The following is a description of a gene set: Mouse Gene Set: GOBP_NEGATIVE_REGULATION_OF_CHOLESTEROL_EFFLUX species: Mus musculus Any process that decreases the frequency, rate or extent of cholesterol efflux. Cholesterol efflux is the directed movement of cholesterol, cholest-5-en-3-beta-ol, out of a cell or organelle., and this is the list of marker genes: Apoe, Srebf2, Irak1, Shh, Abca2, Pla2g10, Egf (NCBI Gene Id 99717)